Given this list of marker genes PREP, EIF5A, EIF2B4, MRPL12, PSMD12, VASH2, BASP1, MAGOH, HBB, CAP1, CCNE1, FAM111A, HELQ, PNPO, PDSS1, MSMO1, CPB1, MVD, B4GALNT2, SREK1IP1, NIFK, ABCB9, BEX2, SPRYD4, RAB8A, PAWR, PDAP1, ADAMDEC1, DNAJC24, GGT1, NME3, PGM1 (phosphoglucomutase 1), TRAPPC2B, DSG2, AHR, S1PR1, SDCBP, PSMD14, H3C4, BMAL1, PPP2CA, AURKA, SLC16A7, PSMD7, BCAT1, SSR1, HIF3A, DUT, PGP, CKAP2, ACP5, ASNSD1 (NCBI Gene Id 54529), NOP9, LRRC59, NMT2, GTF2H2, MRPL42, CIAPIN1, TGM1, BCL11B, CALML3, BUB1, CHD7, GATA1, SF3A3, MRPS33, CENPA, VDAC3, SPCS2, AK3, SYTL3, ZW10, IDH3A, IGF2BP1, MORC4, B4GALT6, CCDC88A, RAP2C, GOT1, ABCG2, SLC35B1, COPS5, TUBA8, FZD9, SUV39H1, TGM2, GZMA, ERGIC2, CHURC1, MRPS7, CDKN1A, SHCBP1, TMEM167A, VRK1, SEPTIN8, PGAM2, RAG1, TIMM13, GRB10, POLR3G (NCBI Gene Id 10622), EEF1E1, PPIC, ESAM, MT1E, ARHGAP39, ATP6V1A, PYCR3, NDUFS1, AMZ2, YEATS4, SLC25A13, TMEFF1, COQ7, UNC13B, TOM1L1, DEGS2, PODXL, PDIA5, PTPN14, CMPK1, MACROD2, RRAS2, CLDN2, MRPS11, PSMB10, AGFG1, GZMB, INSL5, PCLAF, DNMT3B, USO1, DDC, CASP3, EZR, SVIL, CDR2, RPL36A, KLHL9, ANLN, GCLC, SPATS2, WDR36, NCKAP1, TMEM165, UBE2D3, IL5RA, ITGA2B, RARS2, SNRNP25, DTX1, MRE11, TERT, ARVCF, IPO5, DSTN, PTPRF, CACYBP, PRKCQ, HPRT1, ITGA6, AQP1, OTUD6B, EPDR1, CX3CR1, TMEM97, F2R, CA8 (carbonic anhydrase 8), ALOX15, TRIM13, NSUN4, DNAJC11, CCT7, ZNF239, MAD2L1, TXK, TPP2, ERP29, C3orf70, TPD52, CNEP1R1, NUP37, PHB1, NUFIP1, PLPP1, LYPLAL1, H19, TMEM60, POLR2F, MVK, FBLN1, GARS1, TUBB2B, DNA2, HCCS, ATP5MC3, PERP, DPP3, BARD1, DERA, ERP44, here is a description of the gene set: species: Homo sapiens Human Gene Set: GSE24142_ADULT_VS_FETAL_EARLY_THYMIC_PROGENITOR_DN Genes down-regulated in comparison of adult thymic progenitors versus fetal thymic progenitors. from publication Belyaev NN, Biró J, Athanasakis D, Fernandez-Reyes D, Potocnik AJ (PMID 22581009) Development of T-cells provides a unique opportunity to study cell-fate determination due to the accessability and the well defined stages of developmental stages. In order to understand the genetic programs underlying fetal and adult T‑cell fate specification we subjected highly purified fetal and adult T-cell progenitor populations to a genome‑wide transcriptional analysis. The aim was to identify molecular elements that govern T-cell fate specification as a whole but ultimately to isolate elements that were specific for a given population in a specific developmental window.